Given this list of marker genes Tsc22d3, Klf6, Pik3ip1, Hspa1b, Hspa1a, Junb, here is a description of the gene set: Cytokines mediate cell-cell communication in the immune system and represent important therapeutic targets. A myriad of studies have highlighted their central role in immune function, yet we lack a global view of the cellular responses of each immune cell type to each cytokine. To address this gap, the authors created the Immune Dictionary, a compendium of single-cell transcriptomic profiles of more than 17 immune cell types in response to each of 86 cytokines (>1,400 cytokine-cell type combinations) in mouse lymph nodes in vivo. A cytokine-centric view of the dictionary revealed that most cytokines induce highly cell-type-specific responses. For example, the inflammatory cytokine interleukin-1β induces distinct gene programmes in almost every cell type. A cell-type-centric view of the dictionary identified more than 66 cytokine-driven cellular polarization states across immune cell types, including previously uncharacterized states such as an interleukin-18-induced polyfunctional natural killer cell state. studied in species Mus musculus from publication Cui A, Huang T, Li S, Ma A, Pérez JL, Sander C, Keskin DB, Wu CJ, Fraenkel E, Hacohen N (PMID 38057668) Genes negatively differentially expressed in cell type: CD4+ T cell upon treatment with cytokine: C5a in mouse lymph nodes in vivo. Mouse Gene Set: CUI_T_CELL_CD4_C5A_RESPONSE_DN